The following is a description of a gene set: Genes predicted to be targets of miRBase v22 microRNA hsa-miR-6757-5p in miRDB v6.0 with MirTarget v4 prediction scores > 80 (high confidence targets). from publication Chen Y, Wang X (PMID 31504780) species: Homo sapiens Human Gene Set: MIR6757_5P, and this is the list of marker genes: B3GNT3, FAAP20, FKBP10, RAD51AP1, GSG1L, SMDT1, FADS1, SLC31A1, ZNF292, TKTL1, FAM161A, MPDU1-AS1, ZNF468, ZFP82, PBX1, KIAA1549, SLCO1A2, TSFM, IKZF5, KRAS, ADGRL2, THAP10, CD46, WDR72, GPATCH2, NEU3, IFNAR1, RPGRIP1L, ALG8, ZNF558, ZNF219, TMEFF2, IFT80, TSC1, SELE, SEL1L3, CSDE1, SPINK13, WNT7B, TMC8, ATP2B4, BCL2L15, NSD3, LOX, INO80D, FPGT, CYP26B1, UBFD1, CNNM4, FILIP1L, MAP4K5, AMMECR1L, IMP4, KIAA0513, ZNF559-ZNF177, KIF11, ARHGEF38